Given this list of marker genes TRIP10, ASCC3, TCF7L2, TMEM145, CNTN2, ERLIN2, PKD1, ADARB1, KLK8, CD34, WTAP, here is a description of the gene set: studied in species Homo sapiens from publication Chen Y, Wang X (PMID 31504780) Human Gene Set: MIR6820_5P Genes predicted to be targets of miRBase v22 microRNA hsa-miR-6820-5p in miRDB v6.0 with MirTarget v4 prediction scores > 80 (high confidence targets).